The following is a description of a gene set: SLC6A20 encodes the sodium- and chloride-dependent transporter SIT1 and mediates the sodium-dependent uptake of imino acids such as L-proline, N-methyl-L-proline and pipecolate as well as N-methylated amino acids and glycine (Broer & Gether 2012, Schweikhard & Ziegler 2012). The human protein is expressed in the intestine and kidney. A common SNP in the SLC6A20 gene, a 596C-T transition that results in a thr199-to-met (T199M) substitution can contribute towards iminoglycinuria (IG; MIM:242600) or hyperglycinuria (HG; MIM:138500). Overall, mutations in SLC36A2 together with polymorphisms in the modifiers SLC6A20, SLC6A18, and SLC6A19 constitute the genetic basis for these phenotypes. part of: SLC transporter disorders Reactome Pathway: Variant SLC6A20 affecting amino acid transport contributes towards hyperglycinuria (HG) and iminoglycinuria (IG) studied in species Homo sapiens, and this is the list of marker genes: SLC6A20